The following is a description of a gene set: from publication Tyner JW, Uchida O, Kajiwara N, Kim EY, Patel AC, O'Sullivan MP, Walter MJ, Schwendener RA, Cook DN, Danoff TM, Holtzman MJ (PMID 16208318) Genes up-regulated in macrophages: control versus Sendai virus infection. Thus, mouse macrophage cultures were established from PBMCs isolated from wild-type control mice and were inoculated with SeV (Sendai virus) or UV-SeV (UV-inactivated SeV). These microarrays were performed in concert with assays of CCL5 and CCR5 expression, viral replication, and cellular apoptosis. Initial experiments indicated that wild-type mouse macrophages inoculated with SeV exhibit induction of CCL5 mRNA to the highest level of any known mouse gene product, while mRNA levels for CCL5 receptors (CCR5 as well as CCR3 and CCR1) or alternative ligands for these receptors (CCL3 and CCL4) were relatively unchanged by viral infection. studied in species Homo sapiens Human Gene Set: GSE2935_UV_INACTIVATED_VS_LIVE_SENDAI_VIRUS_INF_MACROPHAGE_UP, and this is the list of marker genes: XKRX, ADCY6, ASPDH, SLC16A5, PITPNM2, SELENOP, IDH2, ARHGAP28, MAP4K2, EXT1, EPO, RAPGEF4, JMJD1C, TSPAN13, ST3GAL1, GPR146, FAM156A, CLASP2, MC2R, BBOX1, SIX2, IFT80, TCF7, BIRC5, ACSF2, ST8SIA1, RAB3IP, PDK1, EGR2 (early growth response 2), PPIC, GTF2IRD1, ABCA3, RGS10, SEMA6A, USP44, NMNAT3, SIK1, NPC2, EPHX1, TUBB2A, CLEC18A, C2CD4B, DGKA, ITGAE, SNX30, CHST15, LRRC75A, KDM5A, IGFBP4, IRS2, STT3B, CYTIP, IVL, FAM78A, ISM2, TOX, PLEKHG2, STAMBPL1, PADI3, SLC6A19, S100Z, CCR9, LBH, RHOH, GABRA4, MFHAS1, ADAM11, SPRED1, TMIE, RASGRP1, RALGPS2, ACTN1, RRAS2, DNMT3A, HIF1A, HDAC4, ENG, ADD3, TGFBR3, TREML2, AMPD1, RGS9BP, FETUB, TMEM214, KCNA2 (potassium voltage-gated channel subfamily A member 2), UBE4B, SATB1, KLF13, CDK5R1, PACSIN1 (protein kinase C and casein kinase substrate in neurons 1), CEP295NL, LEF1, USP28, GRIA3, N4BP2, RAPGEF6, ID3, LIPE, PRKD2, SOX1, MGST2, GRIFIN, SYNPO, MAP4K4, DUSP10, MME, IL17RC, TFRC, CCR7, FOXO1, ABCG1, CLSPN, ZIC1, TOP2B, ABLIM1, PMEPA1, ETV3, KLHDC2, MTSS1, TMEM108, DNAJB5, ALS2CL, IKZF2, SH3PXD2A, PELI1, TMEM131, TET1, TRERF1, SELL, PDLIM4 (PDZ and LIM domain 4), LRRC42, LRP1B, PIK3C2A, SIPA1L1, OSBPL1A, ANKRD55, CCR4, NAALADL1, LRAT, GNAS, TBL1X, LRRC8A, SLC12A7, PLEKHO1, CXXC5, NLK, GDF10, DACT1, TCF20, CALCRL, GRK6, TIAM1, PTPN14, RAMP1, TRIB2, CCDC28B, DPP6, NAB2, IFNGR2, SMC4, CD79B, ST6GAL1, IKBKE, DAPL1, COL4A4, CYTH3, IKZF1, RBM38, PRPS2, TIMP2, WNT10A